Given this list of marker genes Abhd5, Pnpla2, Ces1b, Nr1h2, Mup5, Ces1e, Itgav, Mup11, Osbpl8, Crp, Ces1g, Pparg, Clstn3, Ces1a, Ces1h, Mup4, Mup2, Nr1h3, Trem2, Abcg1, Ppara, Ces1d, Ppard (peroxisome proliferator activator receptor delta), Ttc39d, Mup3, Asxl1, Fxn, Ces1c, Mup1, Ces1f, Ttc39b, Ptpn2, Lep, Itgb3, Nfkbia, here is a description of the gene set: Any process that decreases the rate, frequency or extent of lipid storage. Lipid storage is the accumulation and maintenance in cells or tissues of lipids, compounds soluble in organic solvents but insoluble or sparingly soluble in aqueous solvents. Lipid reserves can be accumulated during early developmental stages for mobilization and utilization at later stages of development. species: Mus musculus Mouse Gene Set: GOBP_NEGATIVE_REGULATION_OF_LIPID_STORAGE